The following is a description of a gene set: An increase in size of the third ventricle. Human Gene Set: HP_DILATED_THIRD_VENTRICLE species: Homo sapiens Dilated third ventricle, and this is the list of marker genes: USP7, KIDINS220, DNMT1, TTC5, TAOK1, ASNS, KIAA0586, EIF2B5, ESAM (NCBI Gene Id 90952), MED25, ODC1, ATP6AP2, C2CD3, KCNN2, CSPP1, LARGE1